Given this list of marker genes Kctd9, Fosl2, Ap3d1, Tgfbr2 (NCBI Gene Id 76304), Cd1d1, Ap3b1, Atf2, Itk, Tox, Txk, Zfp683, Psap, Traj18, Prdm1, Zbtb7b, here is a description of the gene set: species: Mus musculus The process in which a precursor cell type acquires the specialized features of a NK T cell. Mouse Gene Set: GOBP_NK_T_CELL_DIFFERENTIATION